The following is a description of a gene set: from publication Payen D, Lukaszewicz AC (PMID 19535937) Human Gene Set: GSE9960_GRAM_POS_VS_GRAM_NEG_AND_POS_SEPSIS_PBMC_UP studied in species Homo sapiens To identify signature genes that help distinguish (1) sepsis from non-infectious causes of systemic inflammatory response syndrome, (2) between Gram-positive and Gram-negative sepsis. Genes up-regulated in peripheral blood monocytes (PMBC): Gram positive sepsis versus mixed infection sepsis., and this is the list of marker genes: MPP1, NTRK2, NAA40, MAFB, NMI, CYB5B, DPY30, INTS3, CPNE1, COA6, MAP4K3, TCF12, SEPHS2, NOP16, PTCD2, POLR2J, ABR, ATF3 (activating transcription factor 3), NID2, EED, LY9, DNTTIP2, KAT2B, TESK1, SH3BGRL2, TOB1, LY6E, SUMF1, CEBPD, WDR81, CXCR4, ICAM2, DNAJC2, PISD, RERE, CSF3R, HMGCL, MOB1A (NCBI Gene Id 80030), VAV1, AXL, PARP1, IRF1, ETFDH, ITSN1, NRP1, EIF3G, JAGN1 (jagunal homolog 1), MLLT3, FABP4, TOMM70, SMN1, ZFP36, PIGF, SUMO3, SKIC8, PITPNC1, DMRTB1, CASP8AP2, DECR1, IRF8, UBA7, TGFBR1, GFER, RBM26, IFIT2, BTK (Bruton tyrosine kinase), SCOC, TBC1D14, PCSK7, SPART, ATXN2 (NCBI Gene Id 8095), STRN3, DUSP1, METTL3, IL6R, JUN, ZFP36L2, SLC4A1AP, NR2C1, B2M, COMMD6 (NCBI Gene Id 170622), UBAP2L, RPS6, CCDC90B, VTA1, MRPL35, PJA1, FAM91A1, MKNK2, RPL34, ARSA, GUCY2D, RPS16, LIMA1, SLC25A11, NUTF2 (NCBI Gene Id 10204), FOSB, ESF1, PRDX1, MACIR, TMCO1, MRPS2, TDP2, SMAGP, SPR, EEF2K, PRMT1, VPS26C, MRE11, NUDT19 (NCBI Gene Id 390916), CCT5, DAXX (NCBI Gene Id 1616), MAGED1, DNAJA3, SNX5, CCT7, TRIM41, ZNF281, KDM3B, SSBP1, EID1, PKP4, TCF4, ISG20, HSF1, PNP, SMARCD2, PPP1R21, DNMT3A, COPG1, MOV10, PDRG1, EEF1D, MRPS17, CXCR2, UPF3B, NDUFS3, SMAD1, PEPD, CMTR2, LDB1, TTC33, PSIP1, FES, MYCBP2, USP18, LORICRIN, SLC12A7, FOXRED1, FGL2, DFFA, RREB1, MRPS18B, RAB18, MTARC2, TSPAN4, SCAF8, RGS14, IGFBP7, ADA, LSM7, TMEM230, PLPP3, PRDX2, EXOSC7, SNX6, ABCC3, IFIT3, FOS, LGMN, FAM50A, SMC3, PTOV1, SNRNP40, PRKDC, DDX3X, RHOB, ASH1L, INTS5, DUSP6, RPS15A, KLF4, MFF, WDR45, AP1AR, MMUT, CHCHD7, S100A4, RARS2, ST6GAL1, EMG1, CIAO1, NDE1, CTBP2, IFI27, DBNDD2, NDUFB5, PKD2, RGL1, ZNF574